The following is a description of a gene set: electronically inferred by orthology from the curated human pathway This event has been computationally inferred from an event that has been demonstrated in another species.<p>The inference is based on the homology mapping from PANTHER. Briefly, reactions for which all involved PhysicalEntities (in input, output and catalyst) have a mapped orthologue/paralogue (for complexes at least 75% of components must have a mapping) are inferred to the other species. Reactome Pathway: PKA-mediated phosphorylation of CREB part of: Calmodulin induced events species: Mus musculus, and this is the list of marker genes: Prkaca, Prkar1b, Adcy5, Calm1, Prkar2b, Prkacb, Adcy8, Adcy7